Given this list of marker genes HSPA1L, AR, FREY1, RIMS1, GARIN4, CCT5, FOLR1, HOXA9, TEX101, NPM2, HOXD10, BPY2, ZPBP2, MCIDAS, PARK7, SPESP1, ATP8B3, GLIPR1L1, ZPBP, GARIN1B, PLA2G10, HEXB, TNP1, ZAN, ALDOA, CCDC136, SPAM1, PLCZ1, CACNA1H, CCT4, BSPH1, AKAP3, SERPINA10, CRKL, GNPDA1, STXBP1, TEX46, EQTN, PAEP, PLB1, DCST2, ADCY3, SLC22A16, BBOF1, ELSPBP1 (epididymal sperm binding protein 1), H3-3A, GMNC, SPINK1, HOXD9, OVGP1, FETUB, FCRL5, CCDC87, ZP1, FOXL2, MFGE8, FOLR2, LYZL6, TMPRSS12, CCDC159, ADAM32, IZUMO1R, LCN6, IGSF8, CCT3, CD46, TRPC3, PLAT, CFAP52, AP3B1, MST1R, ADAM20, IQCF1, CCDC146, CCNO, CFAP119 (cilia and flagella associated protein 119), CNTLN, TARBP2, DEFB126, UNC13B, WEE2, H3-3B, SPACA6, GARIN3, ZP4, DCST1, LLCFC1, SPACA7, UBAP2L, DKKL1, FCRL3, WDR48, CD9, CCT7, OR10J1, FBXO24, ZP3, SPAG1, CECR2, HVCN1, CDK1, UBE3A, BPY2C, GLRB, C16orf92, ANTXR2, COL6A1, IZUMO1, ITPR1, LRRC46, UMODL1, MYH9, PKDREJ, SPACA4, PRND (NCBI Gene Id 23627), PCSK4, RNASE10, ROPN1B, CRISP1, ADAM2, DRC1, OR1D2, POC1B, GLRA1, ACTL7A, SLC9B1, TRIM36, CCT2, SPINK13, TRPC7, STX2, PRSS55, WBP2NL, IQCH, SLIRP, IFTAP (intraflagellar transport associated protein), SNU13, ODAD3, SPAG8 (NCBI Gene Id 26206), CCT8 (chaperonin containing TCP1 subunit 8), TMEM95, NOX5, BPY2B, WDR54, CFAP57, TPST2, IRAG2, SPATA46, XKRY, B4GALT1, SPACA5B, HOXA11, KDM5B, ABHD2, LYZL4, TRPC6, TCP1, FAM170B, VDAC2, ADAM18, DAZ2, HOXA10, ASTL, CLGN, PPP3R2, PLCD4 (phospholipase C delta 4), TMEM81, RAB3A, SMAD4, ADAM21 (NCBI Gene Id 8747), UBXN8, NLRP5, TNP2, ACTL9, ZP2, SPPL2C, SYT8, HYAL3, NPR2, FOLR3, ASH1L, SERPINA5, LHFPL2, LY6K, SPACA3, TUBGCP3, SPACA5, ACR, SYT6, PLCB1, PITHD1, AKAP4, PRSS37, SMCP, SPA17, here is a description of the gene set: Human Gene Set: GOBP_SINGLE_FERTILIZATION The union of male and female gametes to form a zygote. studied in species Homo sapiens